Given this list of marker genes Zfp703, Cacna1i, Kat7, Spry2, Ear1, Ccpg1, Nxf2, Usp15, Gtf2a1, Clec2e, Gorab, Wwp1, Casp8, Ncor1, Akap9, Efna5, Pabpn1, Dpf2, Ino80d, Bche, Arid2, Marcksl1, Spag9, Khdrbs3, Ppp1r1c, Chia1, Ogg1, C1qtnf1, Josd1, Pax3, Brd8dc, Trip4, AU018091, Dapl1, Sult1d1, Gm4791 (NCBI Gene Id 215467), Rps25, Frs3, Ptprg, Ddx6, Tacc1 (NCBI Gene Id 78791), Hdac9, Tnpo2, Syncrip, Pola1, Cnot6l, 9930111J21Rik2, Acsl4, Cpeb3, Mb21d2, Dcaf7, Lactb, Tmprss11g, Onecut2, Mpzl2, Gm4925, Zbtb6, Zbtb39, Entr1, Ptbp3, Thsd7a, Dcaf12, Gid4, Gabarap, Slc30a7 (NCBI Gene Id 99654), Rab33a, Slc6a3, Eloa, Irf2bp1, Far1, Dcaf1, Asxl2, Zfp712, Brd2, Senp3, Nr4a2 (nuclear receptor subfamily 4, group A, member 2), Mef2a, Ncoa4, Mgat4c, Nsl1, Cops6, Pkd2, Bcl11a, Tmem183a, Acmsd, Dlgap1, Rbm27, Dyrk1a, Actbl2, Igdcc4, Plch1, Klhl5, Trim33, Cpeb4, Rabgap1l, Pja2, Celf1, Srpk2, Phf6, Slc39a14, Qki, Rbm4b, Dclk1, Pam, Snx27, Kifbp, Cmpk1, Polr1h, Gatc, AU015228, Ear2, Pafah1b1, Lyzl1, Gnal, Scd1, Nfia, Rere (NCBI Gene Id 68703), Lims1, Mafg, Ptk2, Ppig, Apex1, B3glct, Map3k9, Rab6a, Runx2, Cntln, Ppp1r2 (NCBI Gene Id 74865), Nkx3-1, Top1, Gpr25, Zfp609, Ppp1r3f, Srr, Rell2, Casp6, Ndrg4, Ywhab, Ptar1, Col13a1, Trp53inp2, Usp31, Actr2, Gmnc, Hmg20b, Pgm2l1, Pbx1, Pip4k2a, Oca2, Arfip1, Dnaja2, Zfp871, Rbm3, Cacng2, Blzf1 (basic leucine zipper nuclear factor 1), Bmp5, Btf3l4, Pcmtd2, Mtss1, Gucy2f, Rnf168, Map2k7, here is a description of the gene set: Mouse Gene Set: MIR_6946_5P Genes predicted to be targets of miRBase v22 microRNA mmu_miR_6946_5p in miRDB v6.0 with MirTarget v4 prediction scores > 80 (high confidence targets). from publication Chen Y, Wang X (PMID 31504780) species: Mus musculus